Given this list of marker genes Ube2e3, Phb1, Rpf2, Rgl1, Prag1, Plcg2, Prf1 (NCBI Gene Id 18646), Ppt2, Serpinb9, Mphosph10, Ddx21, Cotl1, Bcl2, Farsa, Gzmb, Gzma, Klrb1a, Serpinb6b, Erh, here is a description of the gene set: species: Mus musculus Genes positively differentially expressed in cell type: NK cell upon treatment with cytokine: OSM in mouse lymph nodes in vivo. Cytokines mediate cell-cell communication in the immune system and represent important therapeutic targets. A myriad of studies have highlighted their central role in immune function, yet we lack a global view of the cellular responses of each immune cell type to each cytokine. To address this gap, the authors created the Immune Dictionary, a compendium of single-cell transcriptomic profiles of more than 17 immune cell types in response to each of 86 cytokines (>1,400 cytokine-cell type combinations) in mouse lymph nodes in vivo. A cytokine-centric view of the dictionary revealed that most cytokines induce highly cell-type-specific responses. For example, the inflammatory cytokine interleukin-1β induces distinct gene programmes in almost every cell type. A cell-type-centric view of the dictionary identified more than 66 cytokine-driven cellular polarization states across immune cell types, including previously uncharacterized states such as an interleukin-18-induced polyfunctional natural killer cell state. Mouse Gene Set: CUI_NK_CELL_OSM_RESPONSE_UP from publication Cui A, Huang T, Li S, Ma A, Pérez JL, Sander C, Keskin DB, Wu CJ, Fraenkel E, Hacohen N (PMID 38057668)